Given this list of marker genes Mtarc2, Tspo, Klf2, Eif3i, Ndufa4, Ccdc134, Ccnd2 (cyclin D2), Ubb-ps (NCBI Gene Id 624036), Krt6a, Krt5, Serpinf1, Ube2l3, Lamtor2, Apoe, BC004004, Spcs3, Sp140l2, Tmem176b, Atp5mf, Rpl13a, Cotl1, Rbm3, Krt14, Ndufa11, Tle5, Uqcrh, Sem1, Gapdh, Ndufa7, Vps25, Tmed10, Tap2, Gpx4 (NCBI Gene Id 625249), Chmp2a, Phgdh (3-phosphoglycerate dehydrogenase), Myh9, Cops6, Gsn, Erp44, Lgals1, Taf10, Spcs1, Ddrgk1, Smdt1, Sdf2l1 (stromal cell-derived factor 2-like 1), Fbln1, Ly6c2, Mzb1 (marginal zone B and B1 cell-specific protein 1), Perp, Psmb8, Sdhd (succinate dehydrogenase complex, subunit D, integral membrane protein), Rexo2, Anxa1, Ddost, Cavin1, Ddx27, Ly6a, Creld2, Mrpl57, Sod1, Jund, Cyba, Mars1, Bcap31, Gpx3, Lgals7, Nme2, Cfl1, Cdc26, Dcn, Reep5, Pafah1b3, Cdkn1a, Serpina3g (NCBI Gene Id 20715), Olfml3, Cst3, Fcgr2b, Ciao2b, Crk, Lyz2, Sparc, H2-Aa, Anxa2, Pi16, Necap2 (NECAP endocytosis associated 2), Ssr4, Krt15, Pou2f2, Prr5, Nt5c, Edem2, here is a description of the gene set: Mouse Gene Set: TABULA_MURIS_SENIS_GONADAL_ADIPOSE_TISSUE_B_CELL_AGEING studied in species Mus musculus from publication Tabula Muris Consortium (PMID 32669714)